Given this list of marker genes CLCN3, ATN1, ERCC8 (NCBI Gene Id 2075), FTL, CP, WDR81, ERCC6 (ERCC excision repair 6, chromatin remodeling factor), CYP27A1, MYORG, SNORD118 (NCBI Gene Id 727676), PDGFB, PDGFRB, GFAP, SLC20A2, DPM1, here is a description of the gene set: Abnormal dentate nucleus morphology An abnormality of the dentate nucleus. studied in species Homo sapiens Human Gene Set: HP_ABNORMAL_DENTATE_NUCLEUS_MORPHOLOGY